Given this list of marker genes TESK1, IDE, C4orf54, PDCD1, UBASH3B, IKZF1, ASB8, PEDS1, SEMA4D, NR4A1, MACROH2A1, CD96, TMUB1, CCR4, TIMMDC1, ZNF707, HSPBP1, CD247, ZAP70, PBX3, ANKRD9, SGSM3, AKAP12, CD6, GALC, BCOR (NCBI Gene Id 57686), CYP20A1 (NCBI Gene Id 57404), NPL, PEX6, BPGM, LMAN2, AKAP1, NCOA2, TRIM35, SLCO3A1, RASSF3, OSBPL3, C5, CPEB1, MRPS11 (NCBI Gene Id 64963), RUNX1, ZBTB7B, TMEM37, FILIP1L, TDP1, AP1M1, NHEJ1, RFTN1, CDK2, RARA, UGCG, DAPK3, ARHGAP27, PIGT, ARHGEF2, SYVN1, SMAP2, HMG20B, NCOA3, LEF1, DFFB, MRPS2, IRF4, C3orf70, ENDOU, CYTIP, GRB2, RASAL1, CD28, FASN, GPAA1, CLSTN1, PIN1 (peptidylprolyl cis/trans isomerase, NIMA-interacting 1), CHST2, C2CD2L, ENO3, B4GALT1, RPS6KA1, CUTA, CAPN3, STAT3, FGD2, TGFB1, BCL6, ST3GAL5, FRYL, LDLRAD4, DDX19B, ITK (NCBI Gene Id 3702), GPN2, SLC35A4, LSP1, RHOBTB2, ABCB9, SHISA5, GPAT4, BCL2, ANKRD23, DAD1, FBXL6, LATS2, PIK3CD, POC1A, IQCF5, FBXW11, PPP5C, DNMT3A, NRGN, CNNM3, PICK1, GPR146 (G protein-coupled receptor 146), DGKZ, GLTP, ANKRD39, HDAC5, PTGER4, BVES, SIT1, ABHD8, SSR2, MFGE8, MACO1, TTC39B, CLPTM1, TOMM40, GM2A, USP19, PIAS4, WDR82, RAB1B (NCBI Gene Id 81876), TSC22D1, HENMT1, CTU2, U2AF2, CAP1, PKP3, PHKA1, GPR65, ERP29, ASB6, STEAP3, WSB2, FARSA, ATP2A2, VARS1, MIER2, FUCA2, TMEM41A, SESN3, MARCHF3, MTSS1, CDH17, SBF1, CAPN7, BMP4, TRIB1, CEMIP2, HIP1R, TMEM273, CYFIP2, ELK3, UNC119B, PLA2G6, STAT5A, PCYT1A, CHST10, PKNOX1, AEN, ASB2, ITGB3, RITA1, POLDIP2, MUL1, DDX21, UBXN6, LRP10, DUSP2, TEC, CCR8, B4GALT3, TG, SHKBP1, HACD3, PGLYRP2, DUSP10, AHSG, RBFA, P2RX7, RNF187, MEPCE, LTA, MAZ, here is a description of the gene set: Genes up-regulated in DO11.10 cells (hybridoma) by expression of transciptionally activating form of HDAC7 and down-regulated by its transcriptionally repressing form. Human Gene Set: KASLER_HDAC7_TARGETS_1_UP Histone deacetylase 7 (HDAC7) is highly expressed in CD4(+)/CD8(+) thymocytes and functions as a signal-dependent repressor of gene transcription during T-cell development. In this study, we expressed HDAC7 mutant proteins in a T-cell line and use DNA microarrays to identify transcriptional targets of HDAC7 in T cells. The changes in gene expression levels were compared to differential gene expression profiles associated with positive and negative thymic selection. This analysis reveals that HDAC7 regulates an extensive set of genes that are differentially expressed during both positive and negative thymic selection. Many of these genes play important functional roles in thymic selection, primarily via modulating the coupling between antigen receptor engagement and downstream signaling events. Consistent with the model that HDAC7 may play an important role in both positive and negative thymic selection, the expression of distinct HDAC7 mutants or the abrogation of HDAC7 expression can either enhance or inhibit the signal-dependent differentiation of a CD4(+)/CD8(+) cell line. species: Mus musculus from publication Kasler HG, Verdin E (PMID 17470548)